The following is a description of a gene set: Genes predicted to be targets of miRBase v22 microRNA hsa-miR-4684-5p in miRDB v6.0 with MirTarget v4 prediction scores > 80 (high confidence targets). species: Homo sapiens Human Gene Set: MIR4684_5P from publication Chen Y, Wang X (PMID 31504780), and this is the list of marker genes: MEOX2, TAB3, STARD4, TCF24, CD109, AMTN, PCBD2, KLHL24, PPHLN1, CIPC, DRC3, PPP6R3, TIMM50, FGD2, ADAM12, DNAJA1, CNTNAP1, ATXN7L1, RAB11B, REPIN1, GINS1, CTCFL, PDZD8, ZFP2 (ZFP2 zinc finger protein), LURAP1, SOST, LRRC51, ZBTB38, ANOS1, RIN2, PNO1, GK5, NFYA, GALNT15 (NCBI Gene Id 117248), ZNF302, ZC3H12B, HSPD1, TOR1AIP2, NOL9, USP28, ZNF705EP, APBB2, ZNF850, JADE1, ZNF737, RGS5, MYOZ2, RPS6KA3, SLC30A7, SLC4A8, GXYLT1, FAM199X, WIZ, EPB41L1, NTNG2, GLIS3, SPATA31A1, CCDC51, CD1D, ZBTB10, PAICS (NCBI Gene Id 647765), MALT1, UMPS, PLCXD1, SCML2, SCOC, GABRB2 (gamma-aminobutyric acid type A receptor subunit beta2), SPATA31A5, CXXC5, RHOBTB3, IRAK2, ANKUB1, GUCY1A2, SCIMP, SLC16A7, HMGB2, ZNF490, DLG3, PDE6A, UVRAG, CASP10, TDRD10, ADAMTS19 (NCBI Gene Id 171019), MYPN, ATRNL1, DNAH14, ZNF195, GID8, UGCG, AMMECR1L, RPS20, SHANK2, SRPX, ZNF33A, SLC6A1, GNA13, USP1, PDZD9 (NCBI Gene Id 255762), ZBTB20, PDK3, RDH12, KLHL5, CHRDL1, ZNF250, ZNF776, MTFMT, PTPN11, ABLIM2, DHX36, RBBP4, YME1L1, ELK4, COX15, RDH10, TRIQK, MATR3, ZFX, KRTAP19-6, SPATA31A7, SLMAP, JCHAIN, GATAD2B, VEZF1, ANP32E, PPP1R14C, ZNF479, STX2, ZNF99, HYKK, JADE2, OGFRL1, CPSF7 (cleavage and polyadenylation specific factor 7), TTC14, CCDC6, FRY, HPSE, SNTG1, LPIN3, RTKN2, NXT1, RBM8A, SPATA31A6, TMEM236, GOLGA5, GATA2, GDAP2, NUDCD1, SPATA31A3, LRP8, ASH1L, USH1G, MDGA2, ZNF677, ZEB2, ORAI2, IGFBP3, TRMT10A, RNF44, OSBP, NYNRIN, PDE4B, TMEM248, EIF5B, TATDN3 (TatD DNase domain containing 3), ZNF181, CEBPZOS, KDM2B, ORC4 (origin recognition complex subunit 4), MIS12, RAB41, PABIR1, SHISA2, ADGRG1, PAIP1, ALG1, APELA, MS4A1, ANO5, AKAP9 (A-kinase anchoring protein 9), SYNPO2, CRYBG1